Given this list of marker genes CACNA1G, FHL1, SCN5A, TBX5, SCN3B, SCN10A, SCN2B, MIR26A1, SCN1B, GJA5, here is a description of the gene set: studied in species Homo sapiens Any process that modulates the establishment or extent of a membrane potential in the depolarizing direction away from the resting potential in an atrial cardiomyocyte. Human Gene Set: GOBP_REGULATION_OF_ATRIAL_CARDIAC_MUSCLE_CELL_MEMBRANE_DEPOLARIZATION